Given this list of marker genes Irgm1, Ncoa4, Gaa (glucosidase, alpha, acid), Plekhm2, Plekhm1, Cln3, Fth1, Lrrk2 (NCBI Gene Id 79409), Lamp2, Sqstm1, Ftl1, Crhbp, Adam8, Map1lc3a, Pik3c3, Lamp1, Mpeg1, Pla2g5, Slc48a1, Pfpl, Map1lc3b (NCBI Gene Id 67443), here is a description of the gene set: species: Mus musculus Mouse Gene Set: GOCC_SECONDARY_LYSOSOME Vacuole formed by the fusion of a lysosome with an organelle (autosome) or with a primary phagosome.